The following is a description of a gene set: Human Gene Set: GOBP_RESPONSE_TO_ELECTRICAL_STIMULUS studied in species Homo sapiens Any process that results in a change in state or activity of a cell or an organism (in terms of movement, secretion, enzyme production, gene expression, etc.) as a result of an electrical stimulus., and this is the list of marker genes: DISC1, SOD2, ADSS2, TACR1 (NCBI Gene Id 6869), HPCA, RAB3A, MMP2, OXT, GHRL, BTG2 (BTG anti-proliferation factor 2), PALM, AKAP12, GRM1, NEUROD2, PRICKLE1, GJB6, GNAT1, TACR2, EPO, NTRK1, FZD3, P2RX7, KCNJ3, NSMF, REST, AKAP9, PTEN, BRD1, GRIA1, HNRNPD (heterogeneous nuclear ribonucleoprotein D), MT-CO1, CALR, MYOG, MSTN, ADSS1, TRIM63, SLC9A1